Given this list of marker genes NUCB1, DLG1, RBM39, USP1, UROD, ECM1, CYCS, UQCRC1, CDK12, SEC14L1, SFPQ, LAMP1, CDCP1, POLD3, ATP2B1, GPX4, CKS2, RNPS1, LIPA, RBX1, RAB6A, TNIP1, KLC1, FAT1, NDUFA13, RAB8A, CAPZA2, CDC25B, RANBP9, AP1S1, HADHA, LARP6, GRHPR, BHLHE40, SRSF3, MFN2 (mitofusin 2), IMMT, MARCKS, KLF9, ATP1A1, AREG, DUSP5, VAMP8, TBC1D8 (TBC1 domain family member 8), VDAC2 (voltage dependent anion channel 2), PAIP1, SGPL1, BSG, ANXA1, PPM1B, LAMA5, RHEBP1, CDK1, POLR3C, TSC22D1, FLOT1, PLPP3, UBE2C, CTNNB1, PLAU, TIMM17A, HAX1, GALNT7, JAG1, ANXA5, H1-0, CST4, PTS (NCBI Gene Id 5805), NPTN, RAB4A, STK39, PRSS23, TYMS, TPI1, LTBP1, ANXA11, ATP5IF1, H2AZ1, COL4A2, HSD17B11, GNAI3, LSM5, COL6A1, TIMP3, SRSF10, RANGRF, ARF4, SF3B3, ATP5F1A, B4GALT3, CDCA3, PHYH, RAB22A, OSBPL9, RAB13, USP15, AP2S1, AP2M1, RFC4, PEG10, ATP5PF, ATP10D, NUDT4, MSRB1, LRP5, PDGFC, RFC5, ANXA7, KDM5B, GRB10, POLI, CPD, F2RL1, here is a description of the gene set: from publication Dittmer A, Vetter M, Schunke D, Span PN, Sweep F, Thomssen C, Dittmer J (PMID 16551631) Human Gene Set: DITTMER_PTHLH_TARGETS_UP Genes up-regulated in MDA-MB-231 cells (breast cancer) after knockdown of PTHLH by RNAi. species: Homo sapiens The effect of endogenous parathyroid hormone-related protein (PTHrP) on gene expression in breast cancer cells was studied. We suppressed PTHrP expression in MDA-MB-231 cells by RNA interference and analyzed changes in gene expression by microarray analysis. More than genes showed altered expression in response to a PTHrP-specific small interfering (si) RNA (siPTHrP). Cell cycle-regulating gene CDC2 and genes (CDC25B and Tome-1) that control CDC2 activity showed increased expression in the presence of siPTHrP. CDC2 activity was also found to be higher in siPTHrP-treated cells. Studies with PTHrP peptides 1-34 and 67-86, forskolin, and a PTH1 receptor (PTH1R)-specific siRNA showed that PTHrP regulates CDC2 and CDC25B, at least in part, via PTH1R in a cAMP-independent manner. Other siPTHrP-responsive genes included integrin alpha6 (ITGA6), KISS-1, and PAI-1. When combined, siRNAs against ITGA6, PAI-1, and KISS-1 could mimic the negative effect of siPTHrP on migration, whereas siKISS-1 and siPTHrP similarly reduced the proliferative activity of the cells. Comparative expression analyses with 50 primary breast carcinomas revealed that the RNA level of ITGA6 correlates with that of PTHrP, and higher CDC2 and CDC25B values are found at low PTHrP expression. Our data suggest that PTHrP has a profound effect on gene expression in breast cancer cells and, as a consequence, contributes to the regulation of important cellular activities, such as migration and proliferation.